The following is a description of a gene set: Mouse Gene Set: chr12D2 species: Mus musculus, and this is the list of marker genes: Gm1995, Eif1ad12, Lrrc74a, Fos, Gm21559, Vipas39, Gm18626, Slirp, Gm17138, Gm8605, Eif1ad15, Pramel51, Erg28, Eif1ad19, Eif1ad6, Gm46995, Angel1, Eif1ad13, Gm18616, Gm37804, Gm46994, Gm21038 (predicted gene, 21038), Zdhhc22, Ubl5c, Sptlc2, Gm5655, Gm2099, Eif1ad18, Gm7104, Gm18620, Noxred1, Gpatch2l, Samd15, Eif1ad8, Eif1ad14, Gm8557, Eif1ad11, Gm18499, Tmed10, Gm8655, Gm46993, Gm6190, 3200001D21Rik, Gm18615, Irf2bpl, Gm8634 (predicted gene 8634), Gm46997, Eif1ad2, Gm18247, Gm18629, Cipc, Jdp2, Gm5789, Eif1ad17, Batf, Gm21569, Gm40477, Gm18632, Gm18631, Gm3742, Gm8504, Eif1ad10, Eif1ad16, Flvcr2, Alkbh1, Ism2, Gm805, Gm2042, Mir3068, Gm33654, Gm46996, Tmed8, Vash1, Gm8607, Pomt2, Gm22004, Tmem63c, Tgfb3, Ttll5, Gm18983, Gm49362, Gm46992, Esrrb, Gm18628, Gm21939, Gm49363, Gm18627, Ift43, Gm21039, Eif1ad3, Ahsa1, Eif1ad9, Gm33312, Gm10095, Gm5442, Gm18625, Gm18617, Gm18619, Eif1ad4, Adck1, Gm8587, Gm18618, Eif1ad7, Gm5955, Gm21937, Gstz1, Snw1, Gm18630, Gm46998, Ubl5b, Oog1, 4930473H19Rik, Gm6566, Gm18624, Ngb